The following is a description of a gene set: species: Homo sapiens Human Gene Set: HP_SPINAL_CORD_LESION Spinal cord lesion, and this is the list of marker genes: CTNNB1, LEMD3, DKK1, SLC33A1, FOXF1, TBX6, UBAP1, SPARC, B4GAT1, NOTCH3, PDCD10, RTN2, NRAS, EP300 (E1A binding protein p300), SH2B1, ACY1, IL11RA, EXT1, CREBBP, MBTPS2, NFIA, RBM8A, RUNX2, NOTCH2, KPNA3, HNRNPK, GLRX5, KDM1A, SETD2, FBXO11, ABCA1, HMGA2, CLP1, FBLN1, VANGL1, COG4, RAI1, DDR2, PIK3CA, POLR1A, EXT2, CCNQ, DDHD2, KRIT1, WASHC5, CCM2